Given this list of marker genes Selenok, Dhx9, Pml, Ifng, Pycard, Usp17le, Ptpn22, Il4, Il12rb1, Zc3hav1, Dtx3l, Nt5c2, Mmp12, Mavs, Sin3a, Eif2ak4, Il12b, Tarbp2, Treml4, Mul1, Il27, Ifna1, Tomm70a, Stat1, Traf3ip2, Zc3h12a, Il23a, Ifnlr1, Pqbp1, Creb3, Trim6, Il15, Rigi, Ercc6, Il23r, Zdhhc1, Trim44, Rnf216, Aim2, Hsp90aa1, Il1b, Parp9, Ccl5, Sting1, Cgas, Zdhhc11 (NCBI Gene Id 71164), here is a description of the gene set: Any host process that modulates the frequency, rate, or extent of the antiviral response of a host cell or organism. species: Mus musculus Mouse Gene Set: GOBP_REGULATION_OF_DEFENSE_RESPONSE_TO_VIRUS_BY_HOST